The following is a description of a gene set: species: Homo sapiens Hyperreflexia is the presence of hyperactive stretch reflexes of the muscles. Hyperreflexia Human Gene Set: HP_HYPERREFLEXIA, and this is the list of marker genes: MED17, PET100, RUSC2, AP4S1, TTC19, RNF113A, SMG9, CTSF, RFC2, SLC2A1, TBX4, KCNA1, NUP54, KCND3, ALG3, KCNJ18, UBAP1, KCNQ3, KATNB1, CAMTA1, SLC31A1, PEX6 (NCBI Gene Id 5190), GEMIN5, ESAM, SLC20A2, CCDC88A, RTN2, AAAS, PEX1, NT5C2, IMPDH2 (NCBI Gene Id 3615), HTRA1, INPP5E, HSPD1, KIDINS220, GOLGA2, SLC1A4, PEX10, SLC1A3, WDR4, PRNP, BEAN1, HECTD4, PEX16, CNBP, EXOSC9, CTNNA2, MT-TE, PSAT1, KNL1, UBE3A, SMC5, ANO10, SAMD9L, CYFIP2, ATXN1, RETREG1, NTRK2, PLP1, CLTRN, NFIX, MCCC1, EXOC8, ZFYVE26 (zinc finger FYVE-type containing 26), GNS, CHCHD10, PDE8B, AGTPBP1, TTBK2, MFSD2A, NDUFA4, SET, NSD1, KIF5A, FBLN5, MORC2, MAN2B1, PANK2, PRR12, NONO, ATXN2, GAD1, TMEM106B (transmembrane protein 106B), ZNF142, CREBBP, PFN1, PLA2G6, PKDCC, APOE, CASK, COG4, GMPPA, MARS2, IL23R, PEX5, RNASEH2C, PTRHD1, RAB18, COX10, CHCHD2, C4A, MFF, TIMM8A (translocase of inner mitochondrial membrane 8A), SDHA, PRDM13, RPGRIP1L, NRAS, COQ9, DCTN1, SIK1, FTL, TRAPPC14, EP300, MICU1, NUP214, SLC6A5, HPDL, NEFH, TAF15, DGUOK, MYL2, GTF2H5, FANCM, SNAPC4, AASS, SCN1B, UBE2T, GFAP, PEX3, ERLIN1, SLC12A2, TRMT10A (tRNA methyltransferase 10A), NEU1, PDGFRB, L1CAM, B4GALNT1 (beta-1,4-N-acetyl-galactosaminyltransferase 1), SEMA6B, HPRT1, WARS1, LETM1, EXTL3, SLC33A1, TLR3, FGF13, SNRPN, MATR3, ABHD16A, ALS2, PAX1, POLR3B, NOP56, HNRNPA1, POU3F4, WASHC5 (WASH complex subunit 5), PARS2, DNM1L, CACNA1G (NCBI Gene Id 8913), SLC38A3, EXOSC8, TCTN2, CCDC47 (coiled-coil domain containing 47), PEX2 (peroxisomal biogenesis factor 2), EEF2, GLDC, NAGA, JAM2, PDGFB, SV2A, PMP22, GJC2, PON1, PCYT2, PQBP1, MT-TV, ELN, MKS1, UROC1, MSTN, DAO, MARS1, SOD1, PAH, GRIA3, MT-TL1, KY, PLXNA1, GGT1, GTF2IRD2, FANCG (NCBI Gene Id 82603), CNP, MEFV, PNKP, WDR62, BCAS3, DPYD, GRN, UGP2, SLC6A19, MRPS34, KCNC3, PYCR2, PITRM1, ELOVL1, UBAC2, NDUFS7, SETX, PEX12, NDE1, MBOAT7, VPS11 (VPS11 core subunit of CORVET and HOPS complexes), RAD51C, ATP1A3, BCKDK, POU4F1, PDYN, SEPSECS, NDUFS8, ADAR, MECP2, FIG4, PLCB1, EYA1, TMEM270, MYORG, ABHD12, ST3GAL5, TSEN2, TARDBP, NSUN2, TAF2, KIF14, ATXN10, GLUL, IBA57, FKRP, AFG3L2, SLC19A3, WARS2, GM2A, NKX6-2, ALG2, GRM7, TANGO2, FTH1, PPP1R15B, COX11, NARS2, GCSH, PPIL1, OSTM1, ISCA2, MAT1A, ZC4H2, SPTAN1, GNB1, GTF2E2, PIGP, DKK1, SLC25A12, VLDLR, SLC32A1, NDUFAF3, RAB3GAP2, KARS1, AMPD2, GDAP2, ACSL4, IRF2BPL, HUWE1, EIF4H, KCNQ2, WDR81, MCCC2, KCNT1 (potassium sodium-activated channel subfamily T member 1), FLRT1, VWA3B, VPS13C, TUBB2B, CRAT, BICD2, PI4KA, FRMPD4, CD40LG, MLXIPL, ARL6IP1, FANCA, PSAP, SLC39A14, DNAJC30, IFRD1, ZFR, ATP5MC3, WLS, COX4I1, PARK7, TICAM1, CLDN11, DYM, NR4A2, CEP135, HIBCH, DNMT1, TARS1, FUCA1, CEP63, IREB2, TMX2, CCNF, TAF13, ERAP1, AHDC1, KDM1A, HEXB, FBXL4, RNU4-2, ZEB2, GTPBP2, RNASEH1, DBR1, WDR73, EXOSC3, FAS, CLPB, SUMF1, ATP1A2, CAMLG, TSPOAP1, CDKL5, AIMP2, NDP, ERCC2, ASNS, ALG11, ATXN7, TREX1, SLC18A2, BSCL2, RFX7, DHX9, FA2H, PRSS12, NSRP1, RNF170, CA8, ADCY5 (adenylate cyclase 5), NALCN, GNB2, DENND5A, MT-ND4, SPTBN2, SPTLC1 (NCBI Gene Id 3302), BAZ1B, ERLIN2, PI4K2A, DYNC1I2, IL10, SDHAF1, LYRM4, RFWD3, GPHN, RAB3GAP1, CCR1, OCA2, PRDM8, KCNMA1, GCH1, MT-TL2, COPB2, NRCAM, CCDC88C, CC2D2A, MFN2, ADSL, PEX14, VPS13D, COQ2, SELENOI, POLR3A, CAMSAP1, SYNJ1, ELOVL4, UCHL1, CCT5, WWOX, STUB1, ERCC3, VRK1, RAD51, SPR, XRCC2, U2AF2, TRAK1, SRPX2 (NCBI Gene Id 27286), MT-ND3, DPM1, SNCA, UFC1, SPART, COQ8A, AP4B1, SASS6, PGM3, AP4M1, CLIP2, VPS37A, RLIM, LRRK2, TRMT5, CEP152, ASPA, FZR1, TAF1 (NCBI Gene Id 6872), GRID2, PRPH, DCC, PCLO (piccolo presynaptic cytomatrix protein), UBQLN2, EBF3, MAG, NUP62, GNAQ, SPAST, TIMM50, PEX26, USP8, GAMT, PRPS1, CHKA, COG5, LMNB1, ERCC1, REPS1, CFAP410, SACS, TLR4, BRIP1, JPH3 (junctophilin 3), SCN1A, ATG5, GLB1, METTL27, TCEAL1, PIGA, STAT4, PEX13, NADK2 (NCBI Gene Id 133686), KIF1A, SLC9A7, EXOSC5, CYP27A1, TFG, POMGNT1, TBL2, QARS1, DARS2, SURF1, TRAF3, COQ4, ABCB7, MICOS13, HTRA2, SEC31A, MMAA, GRM1, MAB21L1, TH, ABAT (4-aminobutyrate aminotransferase), UQCRQ, SLC25A21, NDUFS1, TBCD, SLC6A9, TRRAP, GLE1, NEK1, CWF19L1, ATP6AP2, ENSG00000288330, GTF2I, TBK1, OPTN, TOR1A, GRIN1, ZNHIT3, POMK, ALG9, DTYMK, PINK1, UGDH, MRE11, SCYL1, AP5Z1, AMFR, ATP13A2, TRAPPC6B, CYP7B1, MT-ND1, CASP2, NEUROD2, KDM5C (lysine demethylase 5C), GFM2, AUH, NDUFS2, SLC4A10, ATP8A2, NOTCH2NLC, ARX, IFNGR1, SLX4 (NCBI Gene Id 84464), CPT1C, TRIM8, STIL, UNC93B1, CHMP2B, UNC13A (unc-13 homolog A, NCBI Gene Id 23025), MCM7, VCP, RNF2, ARSA, AARS1, HRAS, POMT2, SPTBN1 (NCBI Gene Id 91654), SPG7, SHMT2, HTT, OPA3, SIGMAR1, SCN2A, CSF1R (NCBI Gene Id 8156), CLP1, FANCB, ITPR1, CHMP1A, DNM1, GLRX5, GBA2, VPS37D, AMACR, ERCC8, LIMK1, GALC, VAPB, SDHB, CDC40, TRAPPC10, GMPPB, ACTA1, PGAP1, CIT, BCAT2, LARGE1, SDHD, MTRFR, ACOX1, CENPE, PHC1, ATXN8OS, STX1A, GLYCTK, HLA-B, MTPAP, NCAPD3, PPP2R2B, MSL3, FANCI, NAA10, VAC14, PPOX, MCPH1, C19orf12, ANXA11, CARS1, OCRL (NCBI Gene Id 4952), CNTNAP1, PALB2, ZIC2, COX5A, PRUNE1, RARS1 (arginyl-tRNA synthetase 1), TREM2, JAM3, PUS3, ABCD1, IER3IP1, MT-ND6, MT-ND2, CACNA1E, TMEM63C, REEP1, MT-ND5, GLRB, TMEM67, ADGRG1, SLC44A1, SLC2A3, IL12A-AS1 (IL12A antisense RNA 1), NFU1, SLC25A46, COQ7, HIKESHI, TUBGCP2, FANCL, OPA1, PIGQ, BUD23, CAV1, AARS2, CYP2U1, FANCC, NIPA1, PRKRA, RFT1, NUP37, ISCA1, ATP5MK, IL12A, ALDH18A1 (NCBI Gene Id 9193), GTF2IRD1, ASPM, TNR, FUS (FUS RNA binding protein), DNAJC6, CDK5RAP2, MAD2L2, SLC16A2, LYRM7, OCLN, MCOLN1, FKBP6, DPAGT1, DDHD2, GARS1, GCLC, POLR1A (NCBI Gene Id 90784), PIGN, DMXL2, GJA1, SLC46A1, KIF1C, MT-TW, HARS1, GPAA1, PRKCG, ABCC9, PTS, NDUFAF4, NFASC, ATXN3, TSEN15, AIFM1, RUBCN (rubicon autophagy regulator), GPT2, ATP6V1A, HYCC1, SPG11, PMPCA, VAMP1 (NCBI Gene Id 6843), NCF1, MAPT, PNPLA6, TTR, KLRC4, TGM6, BCS1L, PIGT, ERCC6, PON3, MT-TN, CAPN1, PEX11B, REEP2, CADM3, PON2, SARS1, PODXL, SLC29A3, FARS2, ABCC8, DDHD1, GAN (NCBI Gene Id 8139), RARS2, FBXO7, SPTLC2, CHP1, FANCE, KCNK4, LBR, COQ5, PEX19, PC, ERBB4, DSTYK, KCNJ6, NUBPL, GJB1, SLC39A8, PRKN, CRELD1, DARS1, ATAD1, H4C5, GFM1, TRIO, ATRX (NCBI Gene Id 6475), EMILIN1, BRAT1, MT-TK, KRAS, GBA1 (glucosylceramidase beta 1), MECR, POMT1, EIF2S3, RNF220, BRCA2, FANCF, METTL5, TPP1, GNAO1 (G protein subunit alpha o1), FANCD2, AUTS2, NDUFS4, KLC2, MPLKIP, TRAPPC11, SQSTM1, MINPP1, ATL1, PMM2, ELP2, TOE1, FDX2, ANG, CDK6, SLC52A3, SPG21, KPNA3, MT-ATP6, GLRA1, PPARGC1A, SYNE1, PAK3, NAA20, DLAT, AP1S2, ERCC4, MRPS25, SLC35C1, BRCA1, SLC25A15, PSEN1, PRRT2, NARS1, DDC (dopa decarboxylase), GLT8D1, PCDH12, SLC25A22, ANKLE2, CACNA1A, AP4E1